The following is a description of a gene set: from publication Hahtola S, Tuomela S, Elo L, Häkkinen T, Karenko L, Nedoszytko B, Heikkilä H, Saarialho-Kere U, Roszkiewicz J, Aittokallio T, Lahesmaa R, Ranki A (PMID 16914566) Genes down-regulated in T helper cells (defines as CD4+) isolated from patients with mucosis fungoides compared to those from normal control donors. Human Gene Set: HAHTOLA_MYCOSIS_FUNGOIDES_CD4_DN species: Homo sapiens PURPOSE: Increased production of Th2 cytokines characterizes Sezary syndrome, the leukemic form of cutaneous T-cell lymphomas (CTCL). To identify the molecular background and to study whether shared by the most common CTCL subtype, mycosis fungoides, we analyzed the gene expression profiles in both subtypes. EXPERIMENTAL DESIGN: Freshly isolated cells from 30 samples, representing skin, blood, and enriched CD4(+) cell populations of mycosis fungoides and Sezary syndrome, were analyzed with Affymetrix (Santa Clara, CA) oligonucleotide microarrays, quantitative PCR, or immunohistochemistry. The gene expression profiles were combined with findings of comparative genomic hybridization of the same samples to identify chromosomal changes affecting the aberrant gene expression. RESULTS: We identified a set of Th1-specific genes to be down-regulated in Sezary syndrome as well as in a proportion of mycosis fungoides samples. In both Sezary syndrome and mycosis fungoides blood samples, the S100P and LIR9 gene expression was up-regulated. In lesional skin, IL7R and CD52 were up-regulated. Integration of comparative genomic hybridization and transcriptomic data identified chromosome arms 1q, 3p, 3q, 4q, 12q, 16p, and 16q as likely targets for new CTCL-associated gene aberrations. CONCLUSIONS: Our findings revealed several new genes involved in CTCL pathogenesis and potential therapeutic targets. Down-regulation of a set of genes involved in Th1 polarization, including the major Th1-polarizing factor, TBX21, was for the first time associated with CTCL. In addition, a plausible explanation for the proliferative response of CTCL cells to locally produced interleukin-7 was revealed., and this is the list of marker genes: DDHD2, UBP1, NPIPA1, LEPROTL1, CNOT2, CRYBG1, ADD3, ABCE1, SKIC3, PEBP1, MRPL3, DDX18, AHSA2P, AVL9, DIMT1, CD81, TSPYL4, RAD21 (RAD21 cohesin complex component), STAT5B, UBQLN2, SNX1, NUCKS1, UBAP2, KLF9, HINT1, PRMT2, TPD52, EIF1AX, SEPTIN6, CALM1, NLRP1, IMPDH2, GORASP2, SNAPC5, TARDBP, WWP1, EVL, RBM26, PPP3CC, CPSF6, TUG1, TMEM123, PCYOX1L, ATIC, MAP4K1, TRIM28, SLC12A7, VAMP1, MALT1 (NCBI Gene Id 10892), CACYBP, PRDX2, MDFIC, FAM162A, NUCB2, ARHGEF18, C1QBP, KIF2A, SHFL, RNF4, EBAG9 (NCBI Gene Id 9166), MT-ND5, NAP1L1, HNRNPA1, CDC23, ZC3HAV1, LY75, ZFAND1 (zinc finger AN1-type containing 1), PAICS (phosphoribosylaminoimidazole carboxylase and phosphoribosylaminoimidazolesuccinocarboxamide synthase), SYNCRIP, FUBP1, NMRK1, MRPL9, RCN2, ATG12, TRAK2, FAM8A1, TRIM33, CCNG1, ITGB1BP1, UGCG, ZBED5, PPP1R2, COX11, DUT (NCBI Gene Id 1854), SLC7A1, NCK2, OLA1, TTC3, IL6ST, METTL3 (methyltransferase 3, N6-adenosine-methyltransferase complex catalytic subunit), SRP72, OSBPL8, RPL31, HNRNPA3, CDC42, RBM8A, YTHDC2, WASHC3, GSPT1, KTN1, LCP2, KHDC4, IPO7, CD69, ICAM2, SEMA4C, LUC7L3 (NCBI Gene Id 51747), NACA, INPP4A, MPRIP, EIF5B, ACTN1, MPHOSPH9, PITPNB, PGRMC2